Given this list of marker genes MS4A1, IRF2BP2, ICOS, TNFRSF13C, CD19, MID1, CD81, NFKB2, TNFSF12, CR2, TNFRSF13B, NFKB1, here is a description of the gene set: Posterior pharyngeal cleft studied in species Homo sapiens Human Gene Set: HP_POSTERIOR_PHARYNGEAL_CLEFT